Given this list of marker genes SLC4A9, ZNFX1, CALB1, CHMP4A, CPED1, NET1, RBCK1, CALU, CNOT6, DNAJC21, SMARCE1, RAD1, ZNF813 (zinc finger protein 813), LINC02171, CMSS1, DDX60L, DNAAF6, PPIH, MOB1B (MOB kinase activator 1B), KCNIP3, LRRC28, POP7, GAR1, POU2AF3, PBDC1, APOBEC4, CD274, BCL2L14, USP25, ARL4A, SPN, ELOVL7, SNRNP35, IMP4, SYCP2, NOP56 (NOP56 ribonucleoprotein), LHX4, UST-AS1, COA6, BOD1, C10orf95-AS1, NGDN, NOP58, CLEC2D, STAT2, PCDH11Y, DCLK3, NRBF2, DENND2C (DENN domain containing 2C), PRDM10, IQSEC2, CARNMT1, SC5D, LILRB2, SNX6, SREBF2, DDX47, JMJD1C, CCAR1, CEP192P1, SKIC3 (NCBI Gene Id 9652), SLC40A1, NEURL3, DHX58, NDUFA9, PPA1, ABCB7, IFNG, OR7A5, CNDP2, PCDHGC5, PSMA2, AGPS, ZNF134, GRSF1, NMI (N-myc and STAT interactor), PRRC1, PPP1R8, RUNX2, EHD4, DNAI4, TSPAN13, PGAM1, ZNF627, PTRH2, ARSB (arylsulfatase B), OASL, CCDC71L, UTP20, RANBP17, PRR5, TOR1B, FMNL2 (formin like 2), GPATCH4, FARSB, DDIT3, CCT4, SARNP, CMC1, PFDN2, SEC31A, VPS35L, GRIN3A, PLGLB2 (NCBI Gene Id 5342), MYOF, PARP14, GPN3, RTP4, FHIT, DAP3, CHADL, IFI16, TPTE, TAF12, PPP4R3A, ADAR, CCR1 (C-C motif chemokine receptor 1), ELF4, FBXO6, LINC00687, ATAD1, NADK, GMFB, CAST, UBL7-DT, RNF139, CDR2, MRPS31, LGALS3BP, AHCTF1, PPP2R2A, PTGDS, RIGI, NRSN2, SAT1, SF3B3, SLC18A1 (solute carrier family 18 member A1), NKX6-3 (NCBI Gene Id 157848), APC, ZFAS1, CKAP5, HERC6, MRPS30, HSPD1, ADGRF3, SUGT1P3, ARIH1, PSMD14, CCNA1, ZNF784, RBM8A (RNA binding motif protein 8A, NCBI Gene Id 9939), PTTG1 (PTTG1 regulator of sister chromatid separation, securin), SIRPB2, BAG1, SMAD2, OPCML, TSSK1B, PTGER1 (prostaglandin E receptor 1), UBAP2, SRP72, STOML1, ERLEC1, METTL8 (methyltransferase 8, tRNA N3-cytidine), RELA, EXOSC10, SRGAP2, LRRC4C, RBM25, C20orf203, COPS2, ROPN1B, LTBP2, ZNF22, CPB1, SLC35E3, ZNF618, PRF1, TANK, CASC22, IFITM2 (interferon induced transmembrane protein 2), MCHR2, PIK3CG, CDK16, PPP2R3C, GTPBP1, RARS1, CFAP126, PTK7, LINC00567, CD3E, STMN1, SYNCRIP, OR1F1, ACTR1A, FRMD3, CSRNP2, CCL19, here is a description of the gene set: Human Gene Set: GSE18281_MEDULLARY_THYMOCYTE_VS_WHOLE_MEDULLA_THYMUS_DN from publication Griffith AV, Fallahi M, Nakase H, Gosink M, Young B, Petrie HT (PMID 20064453) Genes down-regulated in medullary thymocytes versus thymus whole medulla. species: Homo sapiens Interaction of hematopoietic progenitors with the thymic stromal microenvironment induces them to proliferate, adopt the T cell fate, and asymmetrically diverge into multiple T lineages. Progenitors at various developmental stages are stratified among different regions of the thymus, implying that the corresponding microenvironments differ from one another, and provide unique sets of signals to progenitors migrating between them. The nature of these differences remains undefined. Here we use novel physical and computational approaches to characterize these stromal subregions, distinguishing gene expression in microdissected tissues from that of their lymphoid constituents. Using this approach, we comprehensively map gene expression in functionally distinct stromal microenvironments, and identify clusters of genes that define each region. Quite unexpectedly, we find that the central cortex lacks distinctive features of its own, and instead appears to function by sequestering unique microenvironments found at the cortical extremities, and modulating the relative proximity of progenitors moving between them.